Given this list of marker genes GNAS, ACR, CRHR1, GIPR, P2RY11, CAP2, ADORA2B, TMIGD3, EDNRA, GLP1R, ADCYAP1, AVPR2, CAP1, ADORA3, CALCA, here is a description of the gene set: Any process that initiates the activity of the inactive enzyme adenylate cyclase. Human Gene Set: GOBP_ACTIVATION_OF_ADENYLATE_CYCLASE_ACTIVITY species: Homo sapiens